Given this list of marker genes APOM, LRRC39, GARIN3, NRSN1, RHAG, TREH, PMS2, GRIK1, BMAL2, IKZF3, CENPH, SPACA7, SLC25A27, THOC7, KCNH2, UPK1B, CHRNA6, POU3F1 (POU class 3 homeobox 1), ANKRA2, NR6A1, NPHP3, KIAA0232, ZIC1, SLC25A41, TFF2, SLC15A5 (solute carrier family 15 member 5), MMP13, ALS2, CD27, DGLUCY, TNNI2, DDO (NCBI Gene Id 8528), ADGRA1, COA7, THBS4, LCE1A, CLHC1, NAV2, ACTA1, CPA6, MYPN, MS4A2, SLN, RAD54B, SBSPON, PVALB, DEFB4A, FABP1, ACTN2, ITSN1, MYH1, CORO6, SLC22A25, PROX2, MYBPC2, MYOM2, IL16, TRIM63, PCDH10, MYL1, CCDC7, KRT6B, CCDC34, THEM5, SOCS2, MEIOB, SYT2, CECR2 (NCBI Gene Id 27443), SPEG, MYL11, PDLIM3, INSM1, RUFY2, RPGRIP1, DPY19L2, CADM2, PSRC1, TNR, RLN2, PRPS1L1, B3GALT6, TEX21P, EHF, RELCH, DAAM2, GABRB1, KYAT1, CACNA1B, ANKRD23, KBTBD7, SH3BGR, RIPK4, FLRT2, MYF5, GH1 (growth hormone 1), CHIA, ATP2A1, TRAT1, TNP1, PBX4, FAM53A, PIP5K1B, PAX9, CEP128, C2orf80, RSPH4A, TNNC2, MGAT5, FASTKD3, GRIP1, DLK1, CIMIP4 (NCBI Gene Id 339669), CASQ2, LRRTM2, EYA1, TNIP2, C1orf50, PCDH9, SPMIP10, NPAS3, GABRA2, TMED7, SERPINA1, NEXMIF, KCNK1, CABP7, ODAD3, GRIA1, OTC, RYR2, SIM1, PRDM16, DHCR24, MC1R, BCLAF1, PYGM, SLC25A26, LRP2BP, LIPM, CUX2, HAPLN1, CYP1A1, MB, KCND2, USP53, KCNJ3, FAM131B, OSBPL6, FABP6, CTXN3, SEMG1, TRIM17 (NCBI Gene Id 51127), PTPRJ, HEPACAM, PRKCA, EPHA1, POT1, SERPINB2, NLRP4, SPATA16 (NCBI Gene Id 83893), ZIC5, B3GALT1, ADORA2A, CKMT2, ASB15, MYH4, CD28, HSPA4L, OR5B3, RBM46, A2M, C3orf18, SMTNL1, C4orf19, WNT3, CTSL, SEMA3E, TTN, MYBPC1, TTR, GNGT1, HAVCR1, NPY2R, RBFOX1, CLEC2D, PCNT, STAC3, PAPPA, TRIM5, CEACAM4, FCRL1, TNNT3, ZNF729, COL4A4, CRAT, CFTR, TAS1R3, NXPH1, SCRG1, CHRNA9, KLHL41, SMIM17, MYOT, NCAN, COL12A1, AQP5, AK4 (adenylate kinase 4), KCNK9, CFAP206, ZSWIM5, FOXN4, LENEP, METTL21EP, HIF1A, ARPP21, NEB, MYF6, SERPINB5 (serpin family B member 5), TBR1 (NCBI Gene Id 94313), TRDN, UTP23, SNTG1, GDPD3 (glycerophosphodiester phosphodiesterase domain containing 3), DYNLT1 (NCBI Gene Id 6993), USP17L24, POLQ, ELFN2, FOCAD, TMOD4, NECTIN3, HTR7, ASCL1, NMBR, NCAM2, ID4, SLC5A12, SEMA3B, TRIM7 (tripartite motif containing 7), MRAP2, ISL1, SMYD3, SMO, RBM14 (RNA binding motif protein 14), SLC29A4, TNNT2, FARSA, SKOR1, UBE2U, CKM, SUSD5, here is a description of the gene set: Genes down-regulated in mouse stroma of pancreatic adenocarcinoma zenografts after treatment with HhAntag, a hedgehog (Hh) pathway inhibitor. studied in species Mus musculus from publication Yauch RL, Gould SE, Scales SJ, Tang T, Tian H, Ahn CP, Marshall D, Fu L, Januario T, Kallop D, Nannini-Pepe M, Kotkow K, Marsters JC, Rubin LL, de Sauvage FJ (PMID 18754008) Human Gene Set: YAUCH_HEDGEHOG_SIGNALING_PARACRINE_DN Ligand-dependent activation of the hedgehog (Hh) signalling pathway has been associated with tumorigenesis in a number of human tissues. Here we show that, although previous reports have described a cell-autonomous role for Hh signalling in these tumours, Hh ligands fail to activate signalling in tumour epithelial cells. In contrast, our data support ligand-dependent activation of the Hh pathway in the stromal microenvironment. Specific inhibition of Hh signalling using small molecule inhibitors, a neutralizing anti-Hh antibody or genetic deletion of smoothened (Smo) in the mouse stroma results in growth inhibition in xenograft tumour models. Taken together, these studies demonstrate a paracrine requirement for Hh ligand signalling in the tumorigenesis of Hh-expressing cancers and have important implications for the development of Hh pathway antagonists in cancer.